Given this list of marker genes MYOG, MEGF10, EPHB1, KPNA1, JAK2, AKIRIN1, SUGT1, DSN1, NDC80, MSTN, PPARD, SIX1, FGF2, CFLAR, ANGPT1, SIX5, STAT3, PAXBP1, here is a description of the gene set: studied in species Homo sapiens The multiplication or reproduction of satellite cells, resulting in the expansion of the cell population. Satellite cells are quiescent cells that are located between the basal lamina and the plasmalemma of the muscle fiber, which are the main contributors to postnatal muscle growth. In adult muscle, satellite cells become activated to divide and differentiate in response to muscle damage. Human Gene Set: GOBP_SKELETAL_MUSCLE_SATELLITE_CELL_PROLIFERATION